The following is a description of a gene set: Human Gene Set: HP_APNEIC_EPISODES_PRECIPITATED_BY_ILLNESS_FATIGUE_STRESS species: Homo sapiens Apneic episodes precipitated by illness, fatigue, stress Recurrent episodes of apnea that are precipitated by factors such as illness, fatigue, or stress., and this is the list of marker genes: SLC5A7, SYT2, AGRN, MYO9A (NCBI Gene Id 80251), CHAT, SNAP25, CHRNE, COL13A1, SLC25A1, PDHA1, SLC18A3, VAMP1